Given this list of marker genes DHDDS, SETD1B, GABRA1, KCNMA1, SYNGAP1, GRIN2A, GABRB3 (NCBI Gene Id 2562), CACNA1H, JRK, FRRS1L, GABRG2, SLC2A1, NADK2, SCN1A, here is a description of the gene set: Human Gene Set: HP_MYOCLONIC_ABSENCE_SEIZURE studied in species Homo sapiens Myoclonic absence seizure is a type of generalized non-motor (absence) seizure characterized by an interruption of ongoing activities, a blank stare and rhythmic three-per-second myoclonic movements, causing ratcheting abduction of the upper limbs leading to progressive arm elevation, and associated with 3 Hz generalized spike-wave discharges on the electroencephalogram. Duration is typically 10-60 s. Whilst impairment of consciousness may not be obvious the ILAE classified this seizure as a generalized non-motor seizure in 2017. Myoclonic absence seizure